Given this list of marker genes MGAT2, TRPM3, RECQL4, POR, RASA1, GNAQ, CD96, DHCR7, ESCO2 (NCBI Gene Id 5951), RBM8A, EPHB4, GLI3, here is a description of the gene set: species: Homo sapiens Hemangioma, a benign tumor of the vascular endothelial cells with small endothelial spaces, occurring in the face. Human Gene Set: HP_FACIAL_CAPILLARY_HEMANGIOMA Facial capillary hemangioma